Given this list of marker genes Ubb, Rps27a, Josd2, Prkn, Josd1, Vcp, here is a description of the gene set: studied in species Mus musculus This event has been computationally inferred from an event that has been demonstrated in another species.<p>The inference is based on the homology mapping from PANTHER. Briefly, reactions for which all involved PhysicalEntities (in input, output and catalyst) have a mapped orthologue/paralogue (for complexes at least 75% of components must have a mapping) are inferred to the other species. Reactome Pathway: Josephin domain DUBs electronically inferred by orthology from the curated human pathway part of: Deubiquitination